Given this list of marker genes ORC3, DDHD1, LRP8 (NCBI Gene Id 7804), MGST3 (NCBI Gene Id 9272), TAF5, DBT, TJP1, SATB1, CASTOR2, CREBBP, CBLN4, INO80D, ZCCHC8, YBX3, TMOD2, ADAM9, ZBTB34, NEURL4, NRCAM, SPO11, here is a description of the gene set: Genes predicted to be targets of miRBase v22 microRNA hsa-miR-191-5p in miRDB v6.0 with MirTarget v4 prediction scores > 80 (high confidence targets). Human Gene Set: MIR191_5P species: Homo sapiens from publication Chen Y, Wang X (PMID 31504780)